The following is a description of a gene set: studied in species Homo sapiens Calcium-dependent catalysis of the reactions: ATP + a protein serine = ADP + protein serine phosphate; and ATP + a protein threonine = ADP + protein threonine phosphate. Human Gene Set: GOMF_CALCIUM_DEPENDENT_PROTEIN_SERINE_THREONINE_KINASE_ACTIVITY, and this is the list of marker genes: MAPKAPK5, HMGB1, PRKCG, PRKCA, CAMK2N1, MKNK1, MAPKAPK3, MAPKAPK2, PRKCB, CAMK2N2, MKNK2, CAMK4, CIB1